The following is a description of a gene set: studied in species Mus musculus Cytokines mediate cell-cell communication in the immune system and represent important therapeutic targets. A myriad of studies have highlighted their central role in immune function, yet we lack a global view of the cellular responses of each immune cell type to each cytokine. To address this gap, the authors created the Immune Dictionary, a compendium of single-cell transcriptomic profiles of more than 17 immune cell types in response to each of 86 cytokines (>1,400 cytokine-cell type combinations) in mouse lymph nodes in vivo. A cytokine-centric view of the dictionary revealed that most cytokines induce highly cell-type-specific responses. For example, the inflammatory cytokine interleukin-1β induces distinct gene programmes in almost every cell type. A cell-type-centric view of the dictionary identified more than 66 cytokine-driven cellular polarization states across immune cell types, including previously uncharacterized states such as an interleukin-18-induced polyfunctional natural killer cell state. Genes positively differentially expressed in cell type: Macrophage upon treatment with cytokine: IL-5 in mouse lymph nodes in vivo. Mouse Gene Set: CUI_MACROPHAGE_IL5_RESPONSE_UP from publication Cui A, Huang T, Li S, Ma A, Pérez JL, Sander C, Keskin DB, Wu CJ, Fraenkel E, Hacohen N (PMID 38057668), and this is the list of marker genes: Eif4g2, Trim30a, Ifih1, Ccl7, Ccl12, Ccl6, Ddx21, BC005537, Peli1, Ifi204, Ccl9, Agfg1, Cxcl10